The following is a description of a gene set: Genes predicted to be targets of miRBase v22 microRNA hsa-miR-1245a in miRDB v6.0 with MirTarget v4 prediction scores > 80 (high confidence targets). from publication Chen Y, Wang X (PMID 31504780) studied in species Homo sapiens Human Gene Set: MIR1245A, and this is the list of marker genes: MEIOC, SEPTIN6, CYRIA, OPRK1, KLRF1, SRSF8, MSL2, RAVER2, LEPR, EAF1 (NCBI Gene Id 85403), SLFN5, SOD1, MIA3, ZNF250, KRTAP9-9, TBRG1, PGM2L1, CLOCK, TMCC1, FSBP, PURG, RBM46, HNRNPR, AMMECR1L, LCORL, JAG1, RPL34, RAD54B, TMEM199 (transmembrane protein 199), C11orf24, MACIR, APP, AJAP1, CNTN5, SGTB, TRIM22, SMCO3, MYLK3, PRPS2, MBL2, SGMS1